Given this list of marker genes Tnxb, Efemp2 (NCBI Gene Id 74808), Lox, Mfap4, Thsd4, Fbln5, Ltbp4, Myh11, Atp7a, Col3a1, Emilin1, here is a description of the gene set: Assembly of the extracellular matrix fibers that enables the matrix to recoil after transient stretching. species: Mus musculus Mouse Gene Set: GOBP_ELASTIC_FIBER_ASSEMBLY